Given this list of marker genes IFNA17, MED20, 1C, GPC3, ARIH1, IRF3, IFNA16, MAVS, UBE2L6, TLR4, MED25, MED9, MED16, RBX1, L, MED7, RIGI, GPC2, H2BC15, CDK19, G, MED26, UBB, MED27, 1B, IFIH1, IFNA8, TRIM25, IFNAR1 (NCBI Gene Id 3454), GPC4, MAP1B, MED21, SH, IFNA1, CLEC4M, ELOC, ISG15, MED22, HSPG2, IFNA4, SDC2, IFNA21, IFNA10, M, SDC3, MED18, CX3CR1, CREBBP, TLR2, EP300, M2-1, JAK1, CUL5, SDC4, Human respiratory syncytial virus A2, complete genome, CDK8, CD209, ELOB, MED24 (mediator complex subunit 24), MED8, TLR7, GPC5, MED11, P, IFNAR2, MED28, MED10, MED13, TYK2, MED13L, IFNA5, MED29, MED31, GPC6, CCNC, N, IFNA6, IFNA7, OAS2, IFNA14, BCAP31, UBC (ubiquitin C), Human respiratory syncytial virus A, MED4 (mediator complex subunit 4), TLR3, EIF2AK2, BECN1, GPC1, MED17, CD14, IFNA2, MED6, HERC5, MED12 (NCBI Gene Id 9968), MED19, RPS27A, AGRN, UBA52, LY96, STAT2, IFNB1, SDC1, MED1, MED14, F, MED15, TLR6, MED30, MED23, here is a description of the gene set: studied in species Homo sapiens Airway epithelial cells are the primary target for human respiratory syncytial virus (hRSV) and other inhaled pathogens. In response to RSV infection, airway epithelial cells initiate both inflammatory responses and antiviral immune responses to effectively eliminate the virus. Pattern recognition receptors (PRRs), including Toll-like receptors (TLRs) and retinoic acid-inducible gene-I-like receptors (RLRs), detect viral components such as RSV genomic RNA and trigger the production of pro-inflammatory cytokines, chemokines, and type I interferons. Additionally, airway epithelial cells recruit other innate immune cells including polymorphonuclear leukocytes (PMNs), macrophages, and natural killer cells to establish an antiviral environment and facilitate the resolution of inflammation within the lungs. The impact of RSV infection on the host cell transcriptome and proteome is reviewed by Hu et al., 2020. The adaptive immune response controls RSV infection by secreting antibodies or by cytotoxic T lymphocytes (CTLs) that recognize and eliminate RSV-infected cells. RSV evolved strategies to evade or subvert these host responses, allowing an infection to be established and persist within the host. For example, the NS1 and NS2 proteins target the signaling molecules involved in the innate immune response suppressing PRR-induced IFN production and IFN-mediated signaling pathways. Viral SH has been implicated in inhibiting apoptotic pathway, a type of non-inflammatory cell death that limits viral propagation. At the same time, Triantafilou et al. (2013) have reported that viral SH promotes an inflammatory necrotic cell death to release the cell content. Further, the binding of RSV G protein to leukocytes involves the host CX3C chemokine receptor 1 (CX3CR1) and results in blocking signaling and trafficking of CX3CR1-expressing Th1 immune cells to the lungs, facilitating RSV infection. The hRSV NS2 protein induces cell shedding into large airways causing an acute airway obstruction in an animal model of RSV infection through an unknown mechanism. <p>Several host factors contribute to the pathogenesis of RSV infection and its long-term effects, including age, prematurity, underlying respiratory conditions such as chronic lung disease including cystic fibrosis, deficiencies in specific immune components or dysregulated immune responses. In some cases, an exaggerated immune response to RSV infection can affect the host's ability to control viral infection leading to immunopathology. For example, elevated production of Th2-type cytokines (IL-4, IL-5 and IL-13) in response to RSV infection leads to airway hyperreactivity and increased risk of developing asthma after hRSV infection. Reactome Pathway: RSV-host interactions part of: Respiratory Syncytial Virus Infection Pathway